The following is a description of a gene set: species: Mus musculus Mouse Gene Set: GOBP_TRANSLATIONAL_INITIATION The process preceding formation of the peptide bond between the first two amino acids of a protein. This includes the formation of a complex of the ribosome, mRNA or circRNA, and an initiation complex that contains the first aminoacyl-tRNA., and this is the list of marker genes: Eif1ad2, Ythdf1, Eif3j2, Eif1ad8, Ncbp1, Eif2ak2, Fech, Ythdf3, Eif1ad17, Eif1b, Eif4b, D1Pas1, Eif2s2, Paip2, Eif4g3, Eif3a, Dazl, Rps6kb1, Boll, Impact, Alkbh1 (NCBI Gene Id 72618), Eif1ax, Eif2s3x, Eif3g, Abce1, Larp1, Eif4ebp2, Tpr, Eif1ad18 (NCBI Gene Id 193330), Fmr1, Mtor, Eif2b1, Bzw2 (basic leucine zipper and W2 domains 2), Eif3m, Eif3e, Eif1ad12, Abcf1 (NCBI Gene Id 28122), Nck2 (non-catalytic region of tyrosine kinase adaptor protein 2), Eif2b4, Eif1ad, Rxra (NCBI Gene Id 78740), Ncbp2, Polr2g, Pml, Eif4e3, Eif1, Rbm4, Eif3l (eukaryotic translation initiation factor 3, subunit L), Rps6kb2, Eif3f (NCBI Gene Id 66085), Denr, Rpl13a, Eif4h, Dhx29, Akt2, Scrib, Gigyf2, Eif4e, Eif1ad11, Eif3h, Zfp598, Eif2b3, Mtfmt, Ppp1r15a, Eif4g2, Ago2, Paip2b, Mtif2, Eif3i, Klhl25, Ctif, Sh3bgrl, Eif3d, Mtif3, Mif4gd, Npm1, Eif1ad16, Eif2a, Ddx3x, Eif6, Eif2d, Dnajc3, Eif1ad4, Eif4a2, Bank1, Eif4g1, Bc1, Eif3k, Nck1, Eif2s1, Khdrbs1, Mcts1, Eif4e2 (eukaryotic translation initiation factor 4E member 2), Tmed2, Eif3b, Eif5, Bzw1, Eif1ad14, Paip1, Eif1ad13, Eif4ebp1, Eif2b2, Eif1ad15, Ppp1r15b, Eif2ak4, Eif1a, Eif3j1, Eif4e1b, Eif2b5, Eif2s3y, Eif1ad3 (eukaryotic translation initiation factor 1A domain containing 3), Eif2ak3, Eif4ebp3, Eif1ad19 (eukaryotic translation initiation factor 1A domain containing 19), Pkp1, Dhx33, Tnf, Eif4a1, LTO1, Hbb-bs, Ythdf2, Eif1ad7, Habp4, Mcts2, Eif2ak1, Mettl3, Eif5b, Eif3c, Uhmk1, Mknk1, Slbp